Given this list of marker genes BCAR3, SRSF4, MPO, RIN1, ZFHX3, HEY1, GRHL3, EVI2A, BLOC1S1, RABGAP1L, NSUN4, PDSS2, CXCR5, TBPL1, PCYT2, SLC2A3, GABRA6, CAV1, ZBTB25, B3GNT5 (UDP-GlcNAc:betaGal beta-1,3-N-acetylglucosaminyltransferase 5, NCBI Gene Id 84002), ANXA8 (NCBI Gene Id 653145), IL17RE, TMEM109, SLC26A7, PCDHA1, ATP2A2, MINDY1, RNF40, RILPL1, ATP6V0A1, LINC00310, NR3C2, ETF1, LRMDA, GFI1, MKLN1, CYTIP, NEK6, APLNR, WNT8B, CFP, SHKBP1, PAFAH1B1, XCL2, TNFSF13, RBM14, KCNN4, PBX1, MMP9, FDCSP, FAIM2, LINC00649, SEMA4A, RBBP6, TMEM86A, AGPAT4, IL13, RAMP2, PTPN22, LUC7L, CSF2, NRXN1, ARHGAP45, AP5B1, DUSP1, TSPAN17, TP63, CFAP20, TLX2 (NCBI Gene Id 51407), RUNX2, SHOX2, DOK2, RGMA, GRIN2D, PTCH1, C1QTNF6, SUPT16H, BMP7, AZI2, TLN1, NGB, ENTPD3, IL17B, OTP, NLRP3, PRKACA, MAFG, VIM, SMG7, UBE2R2, PITPNC1, FOXF2, LCK, TULP4, TSC22D3, ZNF407, HSP90B1, ITGA10, CTNNA3, PCSK4, HPCAL1, TACSTD2, WDR81, RNF207, CCN1, SP6, TCF7, MIR22HG, WNK4, SREBF2, CHAD, MYBPC2, BCL6, CYGB, HOXB4, SOST, TGM4, TRIB1, TAS1R1, WNT7B, SASH3, SULF1, TBX5, PTPN7, GRAP2, PAPPA, CSMD3, SRSF2, STON1-GTF2A1L, FGD1, NR4A1, CCN5, PURG, PCED1B, HOXB5, SLITRK1, CD6, PPP1R14C, GSE1, SDF2L1, LIMK2, RUNX1, RBL1, IL18RAP, POLG2, KRT10-AS1 (NCBI Gene Id 147184), KPNB1, XCL1, PIK3R1, MACROH2A1, PDLIM3, VASN, ACVR2A, PRUNE1, BOC, MYRF, OTOGL, PAX1, RGS1, ACIN1, EPB41L3, IL17A (interleukin 17A), CREB5, AP1G2, REM2, LRATD1, ADD1, CREM, EREG, HOXB6, HLX (NCBI Gene Id 3142), ZMYND8, CNNM4, CDYL, GATA4, YBX2, GALNT12, BATF3 (NCBI Gene Id 55509), ELAVL3, CTSK, ERG, ARMCX1, HOXB1, BATF, LUC7L3, MRTFA, NSD3, SGIP1, MAP1LC3A, GDPD2, P2RY10, CCDC102A, PIGV, RNF19B, PTK2B, SOX5, ITGB7, PTPRS, FAAP100, CEMIP, EDC4, GPD1, CALR, FOXP3, CTNNB1, BNC2, TRPM8, SLC16A6, WWC2-AS2, DAB1, CD28, MADD, PER1, EYA1, SCRN1, UBALD2, EIF2B3, DLX5, RAG1, ABHD8, MEOX2, HAPLN3, SPDEF, IL17F, ASCL4, PROKR1, CCL2, LIF, SNTB2, CCR1, FLT1, PPP1R12C, FLI1, CRY1, CBL, PDZD2, BTG4, PHF6, GPX1 (glutathione peroxidase 1), MKRN3, LTBP3, DUSP2, EIF5A, TMEM179, PGF, AZIN1, FAM117A, SLA, PI15, NHLRC2, ARHGAP27, ZIC4, NOL4L, PCF11, TSSK2, NOL9, KCNJ1, CPNE1, IL7R, PRSS35 (NCBI Gene Id 167681), IL3, RORC, CD69, RNF43 (NCBI Gene Id 54894), MSI2, TSPAN13, C14orf119 (chromosome 14 open reading frame 119), HHIP, OLIG3, here is a description of the gene set: Genes having at least one occurrence of the motif NNGKNTGTGGTTWNC in the regions spanning 4 kb centered on their transcription starting sites. This matches the RUNX1 transcription factor binding site V$AML_Q6 (v7.4 TRANSFAC). studied in species Homo sapiens Human Gene Set: AML_Q6